Given this list of marker genes C2orf49, LINS1, TIMM8A, FGD2, AFAP1-AS1, QSER1, KIF2A, FPR3, RASGRF1, CBX1, POLR3E, RBCK1, ABL1, RTRAF, CD38, DNPEP, ZNF273, CYP51A1, PNRC2, IFNLR1, COPB2, CDR2, MMAB, GPCPD1, ZBTB9, LINC00592, STMN1, OAS1, NUP62, SAMD10, SP110, ACTR3C, CAPN2, DBN1, CCT7, RTCB, ESCO1, NEURL3, SRGAP2, EXTL2, H1-5, NOC4L, HELZ2, HEATR1, EHD4, FAM170B, PITPNB, MNT, SNX6, TOR1B, RPS6KA6, MYBPC2, STKLD1, NSUN7, GRSF1, ZNF451, BAG1, ZNF321P, USP36, DIS3L2, EXOSC9, SRGAP2C, KCTD19, DHX37, RIN2, COA6, C21orf91, THOC2, IFIT1, PRRC1, ANKRD1, SMOC1, LBHD1, ITGB8, SLC38A7, PWAR5, LILRB2, USP25, SPPL2A, MMRN1, CENPJ, SOX4, LCORL, ANKRD36C, LEO1, UBAP2, MTMR7, ZNFX1, COL8A1, NOL11, MCU, LHFPL3, RRAGA, PUM1, BCL2L14, MRPS14, IMP4, OASL, EBNA1BP2, PSMA2, TIPIN, PTTG1, CCDC50 (coiled-coil domain containing 50), LGALS3BP, ZZZ3, SIRPB2, CCT4, MOB1B, ATP13A1, SLC31A2, TPH1, DDX60L, DCAF1, TMEM268, SC5D, MED21, LINC00460, IWS1, DERL2, CYB5R4, TBC1D23, HSPA1A, TRIM26, CSRNP2, SUGP2, PPP2R3C, EAF2, ENSG00000289161, H3C12, DNAJA1, TROAP, MIR21, AGPS, ADSL, NMNAT1, SULT2B1, TLK2, PML, ARIH1, UTP20, DLK2, DTX4, GPR160, PPA1, RRAGD, WDR12, FMNL2, HGS, FSCN1 (NCBI Gene Id 6624), BTG3, SIX1, RNASEH1-DT, NSUN3, SSTR2, KLHL9 (NCBI Gene Id 55958), DTX3L, NDUFA9, RNF31, ZC3H10 (zinc finger CCCH-type containing 10), RGL1, SERPINB5, SAT1, NCEH1, CLUHP3, MRPS30, AK2, METTL21A, RIF1, DCAF13, CETN2, MMP16, CAMK2N1, BRSK2, SIGLEC6, SSR1, MRPL15, GUSBP2, FGL2, MED25, GNB2, APOL6, SP140L, MRPS31, GABPB1, KRT12, MT2A (NCBI Gene Id 4502, metallothionein 2A), ZMYM2, ZNF618, CKAP4, IFITM2, NHEJ1, ITGA7, FNDC10 (NCBI Gene Id 647347), here is a description of the gene set: species: Homo sapiens Interaction of hematopoietic progenitors with the thymic stromal microenvironment induces them to proliferate, adopt the T cell fate, and asymmetrically diverge into multiple T lineages. Progenitors at various developmental stages are stratified among different regions of the thymus, implying that the corresponding microenvironments differ from one another, and provide unique sets of signals to progenitors migrating between them. The nature of these differences remains undefined. Here we use novel physical and computational approaches to characterize these stromal subregions, distinguishing gene expression in microdissected tissues from that of their lymphoid constituents. Using this approach, we comprehensively map gene expression in functionally distinct stromal microenvironments, and identify clusters of genes that define each region. Quite unexpectedly, we find that the central cortex lacks distinctive features of its own, and instead appears to function by sequestering unique microenvironments found at the cortical extremities, and modulating the relative proximity of progenitors moving between them. from publication Griffith AV, Fallahi M, Nakase H, Gosink M, Young B, Petrie HT (PMID 20064453) Human Gene Set: GSE18281_SUBCAPSULAR_VS_CENTRAL_CORTICAL_REGION_OF_THYMUS_UP Genes up-regulated in thymus cortical regions: subcapsular versus central cortical.